The following is a description of a gene set: Abnormality of the male external sex organ. species: Homo sapiens Human Gene Set: HP_ABNORMAL_PENIS_MORPHOLOGY Abnormal penis morphology, and this is the list of marker genes: GNA11, PEX10, RREB1, PEX14, SIM1, CHD4, ZFPM2, DHCR7, NXN, NDNF, SCN2A, ATP6AP2, NSUN2, RNASEH2A (ribonuclease H2 subunit A), SCUBE3 (signal peptide, CUB domain and EGF like domain containing 3), BBS12, KAT5, BRAF, HERC1, RPS19, ADAR, HERC2, FANCG, PTPN11, DPYSL5, RNF113A, FRAS1, PNKP, MBD5, NSD2, SOX4, CDON, RPL15, CRIPTO, FIG4, WNT7A, ADAT3, NODAL, EHMT1, TACR3, PRDM16, SMARCE1, ELN (NCBI Gene Id 2006), GMPPB, DACT1, SMO, SNORD116-1, CENPT, APC2, MAX, ZPR1, STAR, ARMC9, MINPP1, EVC, ACTA1, CUX1, PRKCZ, GH1, GLYCTK, PTDSS1, CDH2, B9D2, ANOS1, PAX6, ESCO2, LHB, LMX1B, STX1A (NCBI Gene Id 6804), SHH, EIF4H, FANCC, SIX3, HBA1, ERCC2 (ERCC excision repair 2, TFIIH core complex helicase subunit), SRD5A2, THOC6, SRRM2, TRIP13, LFNG, HYLS1, PEX13, RFWD3, PRKDC, SMARCA2, COL4A1, WBP4, PRPS1, KISS1, TSPYL1, FANCM, SRA1, PTEN, ALG12, TMEM94, ERCC8, LARGE1, TERC, ERCC6, RPS29, GLI1 (GLI family zinc finger 1), DVL1, MEGF8, PRKACA, DMXL2, PITX2, MAD2L2, GTF2IRD2, HMGA2, CYB5A, IFT80, MTM1, BUD23, EBF3, RTTN, KRAS, FOXF1, POLR1D, KDM1A, TBL1XR1, PROK2, WNT4, CUL4B, SOX10, HEPACAM, PRDM13, MLXIPL, ADA2, GTF2IRD1, CYP17A1, PWRN1, CCDC141, PWAR1, EXT2, FKTN, AXL, BLTP1, MED12, RPL26, CDH11, ZEB2, B3GLCT, AKT1, CUL7, DHODH, INSR, ARX (NCBI Gene Id 619216), OTX2, GPC4, SPEN, FANCL, FANCF, RNASEH2C, CEP290, NIPBL, SALL1, SETD5, CPE, DAG1, ANKRD11, TMEM270, HNRNPH1, NSMF, DNAJC30, PNPLA6, SEMA3A, SUFU, DYNC2I2 (NCBI Gene Id 89891), NCF1, UBR1, FANCD2, PEX16, OPHN1, FREM2, UFD1, KDM5B, PEX6, PBX1, RPL10, LMNA, RPL18, SGPL1, CSPP1, TBX3, RPL5, SDHC, RPL11, SMG8, HID1, NR5A1, HBA2, FOXH1, SMARCC2, ACTB, SLC29A3, BBS7, PIEZO2, BCOR, SUZ12, VAMP7, POMK, RAB3GAP2, H4C9, RPL27, FGF8, RYR1, SOX9, PLCB4, BBS10, ARID1B (NCBI Gene Id 645070), MKRN3, TCF4, RPL8, RTEL1, SCLT1, TERT, POFUT1, MAP2K1, ATR, KIAA0586, POMT2, TONSL, DCC, RPS27, TRPM3 (NCBI Gene Id 80036), DNAJC19, ZIC2, GHR, COMT, OGT, DNA2, BRIP1, GRIN1, COLEC10, RNASEH2B (NCBI Gene Id 79621), SIN3A, FKRP, SMC3, NDUFA8, TTC8, TOE1, TRIM8, MYMX, B4GAT1 (NCBI Gene Id 11041), MAMLD1, SC5D, DVL3, HSD3B2, ISL1, KLLN, RAD51C, TBC1D20, DUSP6, SIK1, ROBO1, RNU7-1, TWIST2, RNU12 (RNA, U12 small nuclear), RPL9, MKKS, PEX26, CDC42, LAMA5, WASHC5, USP7, LHX4, ORC4, LSS, GLI3 (NCBI Gene Id 2737), HS6ST1, TRIM28, TCOF1, FGFRL1, ATAD3A, SKIC3, SOX11 (SRY-box transcription factor 11), IL17RD, CTCF, FAT4, MAPRE2, BAZ1B, KLF1, DYNC2LI1, C2CD3, DCHS1, RAB18, PAFAH1B1, TBX4, ORC1, TBL2, SRY, KMT2D, SCN1B, PIGP, MED12L, GRIP1, SKI, PLAG1, USP9X, RIPK4, MYMK, CCDC28B, FANCI, H19, OBSL1, SATB2, TSR2, PDE4D, EIF4A2, MAB21L1, POLE, TAF6, FDFT1, AFF4, WDR35, TAC3, ERMARD, NOP10, RPL35A, CRPPA, PTCH1, CLMP, TBX1, SEC24C, PEX19, CDKL5, COX7B, SIX6, REST, B3GALNT2, CFAP418, ARL6, SPRY4, POGZ, HLA-B, ZMIZ1, CTBP1, NR0B1, GATA4, NOTCH2 (NCBI Gene Id 55574), HNRNPR, WRAP53, RAB3GAP1, LSM11, MESP2, UBE4B, RLIM, SMS, IFT172, NDUFA6, COL3A1, FKBP6, LUZP1, SNORD115-1, GRB10, DDX6 (DEAD-box helicase 6), NDUFB11, ARID1A, MECP2, SOX3, TUBB, METTL27, TCF12, CASZ1, NEUROD2, CYP11A1, NSD1, SEMA3E, ATP6V1A, PAICS, PALB2, SSR4, SDCCAG8, PSMD12, POMGNT1, ROR2, CYP11B1, BBS1, RPS24, PRRX1, KRT5, ARVCF, FANCA, HEATR3, RFC2, IFIH1, RSPO1, RAD21, NKX2-1, RNU4ATAC, DISP1, SLC32A1, RAC1, NHP2, CASK, EIF2S3, FILIP1, ATP6V1E1, NPAP1, MID1, DCAF17, ERCC4, FZD2, ECE1, KDM5C, TYMS, BBS4, KAT6B, KCNH1, DPP9, POLR1B, DKC1, RPL35, DTYMK, RPS15A, GNAO1, HCCS, LMOD3 (leiomodin 3), FOXC1, CPLX1, ARL6IP6, PARN, IFT74, PEX2, PEX3 (NCBI Gene Id 8504), PSPH, CARS1, UBE2T, SCAPER, GLI2, RPS20, KLHL15, ZMYM2, STXBP1, GNB2, NAA10, STT3B, VAC14, FBXL4, CEP152, TGIF1, POMGNT2, FAM111A, UBE2A, BBS5, MYT1L, CDT1, FGFR2, DIS3L2, CREBBP, DHX37, RPS10, MAGEL2, SLC25A22, TAPT1, SEC23B, DYNC2I1, LMNB2, ABL1, FEZF1, KISS1R, JMJD1C, LRPPRC, LEP (leptin), COG5, PEX1, VPS35L, XRCC4 (X-ray repair cross complementing 4), PDPN (podoplanin), HES7, ANK1, FGF17, USF3, HNF1B, TP63, WNT5A, EVC2, BDNF, PTPRF, SLC25A10, RPS17, NDUFB7, FERMT1, MKS1, CDC42BPB, FGFR1, MADD, CTC1, BBIP1, RXYLT1, SMARCA4 (NCBI Gene Id 6597), AR, TFAP2A, DYNC2H1, STT3A, PUF60, YWHAE, MED25, UBA1, DYRK1A, WNT3, ALKBH8, TREX1, NPHP1, CLIP2, SOX2, BRCA1, PIK3CA (NCBI Gene Id 5290), CDCA7, TMEM63A, RERE, SPTBN1, PQBP1, FANCE, MCTP2, MAB21L2, KIAA0753, LHCGR, HOXA13, THOC2, POMT1, IGF2, GNRH1, EFNB1, MMP23B, KATNIP, TBX22, RBBP8, GPC3, ZMYM3, PSENEN, NHLH2, CDKN1C, RAF1, ZFX, PUM1, RPS7, GPR161, PIGG, SIAH1, TRRAP, KDM3B, DLL1, VPS37D, TOGARAM1, KDM6A, SDHD, OTUD5, RAD51, KLHL41, FLRT3, CEP19, DHDDS, XRCC2, SYNGAP1, GRM7, BRD4 (NCBI Gene Id 90616), PROKR2, SPRED1, ARNT2, POGLUT1, PHF6, TBCE, TINF2, SMARCD1, BBS2, LZTFL1, EP300, SMC1A, FGD1, WWOX, CDC45, GTF2I, CHD7, PSMB10, HOXD13 (NCBI Gene Id 7859), PEX12, SLX4, KANSL1, LIG4, WDPCP, ACBD6, WT1, CAMK2A, NEB, NELFA, MYH3, GAS1, CILK1, ARID2, POLR3A, IFT27, RIPPLY2, EZH2, SMARCB1 (SWI/SNF related, matrix associated, actin dependent regulator of chromatin, subfamily b, member 1), SAMD9, SRCAP, CDC6, LETM1, RPS26, ATRX, H4C11 (H4 clustered histone 11), RSPO2, KIF7, TMEM70, GABRD, EPG5, BICRA, USB1, PIGA, CHRNG, DPF2 (NCBI Gene Id 5977), ZMPSTE24, SLC25A24, GATA1, UBR7, HDAC8, FLNA, BBS9, MTOR, FANCB, RPS28 (ribosomal protein S28), DCX, COG1, ALMS1 (NCBI Gene Id 7840), PPP1R12A (NCBI Gene Id 4659), CCDC8, NPM1, MBTPS2, NDUFS4, SETBP1, INTU, SUCLG1, NEK1, HSPG2, MYRF, GATAD2B (GATA zinc finger domain containing 2B), CEP41, SLC31A1, ZNF699 (NCBI Gene Id 374879), ARCN1, PEX11B, PCNT, TRIM32, KCNA1, GNRHR, PSMC1, DLL3, CTU2, GMNN, ALX4, SMAD4, SMCHD1, HIRA, MAP3K1, GRIA3 (NCBI Gene Id 2892), AHDC1, PIGQ, RPL31, KLHL40, FOCAD, ORC6, CCDC22, POU6F2, INPP5E, WDR11 (WD repeat domain 11), BRCA2, CYP21A2, HUWE1, PEX5, CHRNA3, KCNAB2, KIFBP, GP1BB, LIMK1 (NCBI Gene Id 3984), PIGN, SLC30A7, SDHB, COLEC11, PHF21A, SAMHD1, BUB1B, PRKACB, POR, POLR1C, HESX1